Given this list of marker genes Sprr3, Arpin, Btaf1, Hamp, Shisa6 (shisa family member 6, NCBI Gene Id 380702), Sim1, L3mbtl4, Zc3h4, Dera, Fev, Cadps, Fbxo43, Zfp595, Dipk2a, Eif6, Ints8, Glp2r (NCBI Gene Id 93896), Eif2s1, Rbm28, Ywhah, Lpin1, Cyp1a2, Unc5d, Gstm3 (glutathione S-transferase, mu 3), Brcc3, Prkn, Gpbp1, Srf, Rfx7, Klhl1, Tmem67 (transmembrane protein 67), Ube2k, Serinc5, Nalcn, Rufy2, Synj1, Rsrc1, here is a description of the gene set: from publication Chen Y, Wang X (PMID 31504780) Mouse Gene Set: MIR_3092_3P Genes predicted to be targets of miRBase v22 microRNA mmu_miR_3092_3p in miRDB v6.0 with MirTarget v4 prediction scores > 80 (high confidence targets). studied in species Mus musculus